The following is a description of a gene set: species: Homo sapiens Any process that activates or increases the frequency, rate or extent of alpha-beta T cell proliferation. Human Gene Set: GOBP_POSITIVE_REGULATION_OF_ALPHA_BETA_T_CELL_PROLIFERATION, and this is the list of marker genes: LGALS9, HLA-A, IL18, CARD11, SYK, HLA-E, CD3E, CD28, RIPK2, TGFBR2, EBI3, ZAP70, TYK2, CCR2, XCL1, CD81, RASAL3, PRKCQ, JAK2, IL12B, CD55, TNFSF4, PTPRC, IL23A